Given this list of marker genes NEK9, CIAO1, IGF2, DYNLT1, MED6, NLRP1, POLR3G, HAP1, ENSG00000293855, TRIM16, NAALAD2, OSMR, ZBTB43, AIFM1, FBXL5, FKBP2, MN1, ELOVL2, DLG2, ZNF646, ST18, BCL2L2, EZR, TLN2, PRSS16, IQCK, RIT2, PRKCH, S100A2, CRIM1 (cysteine rich transmembrane BMP regulator 1), BRCA2, TOP2A, RPLP1, ATP6V0E1, GPR183, MTMR4, MAPKAPK2, TPSAB1, ANPEP, WT1, ZNF354A, DUSP2 (dual specificity phosphatase 2), RAMP1, S1PR2, SDC4, RRAD, LFNG, POFUT2, EPHB4, USP19, NACA, FKBP6, RPN1, ATP2B1, FLT1, HOMER2, KRT32, RPS29, HTR7, HARS2, RPL13A, CD99, NFATC3, TBR1, HSPB1, FRMD4B, CD99P1, ZBTB39, PPP1R16B, CTAG2, ETV3, ACTN1, RBM14, PSMD7, GRIP2, MNAT1, CD52, USP9X, TPT1, PCMT1, DHFR, SLC38A10, RHBDF1, TIMP1, GH1, TMEM109, GP5, OMD, RS1, AOC4P, MEST, PFKP, TSC22D1, MTUS2, GNA15, FADS3, CBFB, ADAM28, BTAF1, VCY, NBR2, SPEN, AVPR1B, RPS17, IDS, RGP1, OPRM1, RER1, TAF7, RIBC2, RABGGTB, NCK2, TOR1B (NCBI Gene Id 84822), TUBB2B, NFIB, HTR4, PCDH8, NEMF, BCAM, RGS17, ID3, DPY19L1, FLRT1, APOB, IMMT, SPTLC1, PRH1, CDH16, GLB1, ATP6V0E2, ITM2A, KRR1, DMD, KCNS1, PTMA, EMP1, SRP19, DUS4L, RPS18, CLEC16A, TIAL1, SPCS2, SPP1, SPRYD7, LYN, WEE1, NUP42, NT5E, TFCP2, GHRHR, GNS, PXDC1, DYRK1A, CBARP, USP8, RPLP2, ERG, MAP2K5, SPARC, PML, SEPTIN6 (NCBI Gene Id 23157), ZNF710-AS1, ZMPSTE24, ADCY6, CYTH1, VPS13A, ARHGEF12, SFTPD, PPIL2, TMSB10, ARHGEF7, ALX1, PPP2R2A, ZNF23, RPS16 (NCBI Gene Id 6217), PTPRJ (protein tyrosine phosphatase receptor type J), CSNK1E, FKTN, HNRNPK, RPL34, SCN4A, VIM, SPRED2, MPZ, SLC4A7, TNP2, CAT, MAPKBP1, RRP8, MED20, KIF23, RPS13, PRNP, SLC18A1, ALDOB, RHOA, TAF4B, MROH5 (maestro heat like repeat family member 5 (gene/pseudogene)), SELE, SCAF8, HDGFL3, HNRNPAB, SAR1A (secretion associated Ras related GTPase 1A), ABCC2, CDK11B, VPS72, ZNF318, PRKACG, ZIC1, STK25, ETF1, PPIH, RLIG1 (RNA 5'-phosphate and 3'-OH ligase 1), UBE2C, RPL19, SCHIP1, RUNX1, AR, MELTF, IFRD2, PARP2, ZNF787, MYH11, CYP2C8, ASH2L, PI4KB, RERE, ACOX3, BIN1, EGR3, RNASEH2B, THOC2, H2AC16, KLHL25, DOCK4, TACC1, DPYSL3, ZCCHC14, MMP1, KPNA5, ARIH1, IRS1, DGKB, SAC3D1, CCND2, PRKY, ZNF143, NR4A3, COL5A2, AKAP13, PPT2, F7 (NCBI Gene Id 14068), ECH1, ZFP69B, TRAPPC3, CUL1, S100A10, ITSN2, B2M, PABPC1, DTNA, TM9SF4, OPCML, CD1C, PKD2, CCKAR, CLEC10A, BAZ2A, LRP8, RPLP0, CDR1, CD9, RPL37, RPS6, RAD51C, CDK2AP2, FOXO1, MSH6, XRCC4, PTPRE, TST, RB1CC1, KIFC1, F2, NR4A1, PKP3, GAB1, MDH2, POU2F2, H2BC21, DGKD (NCBI Gene Id 8527), CAP2, LPIN1, RBM15B, STK10, KRT4, RPS4X, ZDHHC3, COX7A1, SLC6A11, SRSF8, RPL23A, RPL13, EXPH5, ANGEL2, ACSL6, RBPMS, PLS3, CHD1, ELF3, TAF1, PMP22, LRP6, RPS27, LGALS9, SPRY2, HSD17B4, CDKL5, COPB2, GNAI1, EEF1A1, PNN, ARID5A, LGI1 (NCBI Gene Id 9211), NDUFAF1, LY6G6C, CTRL, NTRK1, ME3, ACVR1B, DHX38, FASTKD2, ABCB9, PGRMC2, HSPA6 (NCBI Gene Id 3310), CPS1, OIP5, RBM3, RPS20, ALB, SH3GL2, KCNA5, SOX2, ERBB4, RBM25, UBC, RBM39, TRAF5, SLC25A40, TSHR, ARL4C, CLIP3, PPM1G, COL10A1, TOR1A, PCP4 (Purkinje cell protein 4), CYP2E1, HADHB, PDHA2, DIDO1, DLEC1, HSPA1A, ACOX1, RPL37A, GBP2, NF1, NR3C1, ICAM5, OTUB1, DHRS3, DYNC1H1, CACNA1D, CSNK1D, ZNF783, SMAD6, SFSWAP, ACAA2, ATP12A, UCP3, DNAH3, ING2, RPL32, NUP50, RPL27A, MFAP5, ARF6, PTHLH, TLL2, RNF167, GTF2H4, PTGER3, RPL31, H2AZ2, ITPRID2, HLX, KRT16, GTF2H2C, PNLIPRP1, KRT13, CDKN3, PRPF40A, LY6E (lymphocyte antigen 6 family member E), MRPS18B, PMAIP1 (phorbol-12-myristate-13-acetate-induced protein 1), MON2, CDC40, RAB11FIP3, MOK, UBXN2B, TRHR, CD72, here is a description of the gene set: Human Gene Set: YAGI_AML_WITH_INV_16_TRANSLOCATION Genes specifically expressed in samples from patients with pediatric acute myeloid leukemia (AML) bearing inv(16) translocation. Most patients with acute myeloid leukemia (AML) enter complete remission (CR) after treatment with chemotherapy, but a large number of them experience relapse with resistant disease. To identify genes that are associated with their prognoses, we analyzed gene expression in 54 pediatric patients with AML using an oligonucleotide microarray that contained 12 566 probe sets. A supervised approach using the Student t test selected a prognostic set of genes, some of which are associated with the regulation of cell cycle and apoptosis. Most of these genes had not previously been reported to be associated with prognosis and were not correlated with morphologically classified French-American-British (FAB) subtypes or with karyotypes. These results indicate the existence of prognosis-associated genes that are independent of cell lineage and cytogenetic abnormalities, and they can provide therapeutic direction for individual risk-adapted therapy for pediatric AML patients. from publication Yagi T, Morimoto A, Eguchi M, Hibi S, Sako M, Ishii E, Mizutani S, Imashuku S, Ohki M, Ichikawa H (PMID 12738660) species: Homo sapiens